Given this list of marker genes PRDM14, ZIC3, PIWIL2, TFAP2C, NANOS2, here is a description of the gene set: Human Gene Set: GOBP_GERM_LINE_STEM_CELL_POPULATION_MAINTENANCE Any process by which an organism or tissue maintains a population of germ-line stem cells. studied in species Homo sapiens